The following is a description of a gene set: Genes up-regulated in comparison of control CD4 CD8 thymocytes versus those after stimulation with anti-Valpha2 antibodies. Comparison of gene expression changes in CD4+CD8+ thymocytes following engagement of TCR with anti-Valpha or Vbeta antibodies studied in species Homo sapiens Human Gene Set: GSE1448_CTRL_VS_ANTI_VALPHA2_DP_THYMOCYTE_UP from publication Niederberger N, Buehler LK, Ampudia J, Gascoigne NR (PMID 15661827), and this is the list of marker genes: IFNGR2, ARPC5L, STAG2 (NCBI Gene Id 10735), DPP6, EIF2S3, DNPH1, HPN, ISOC1, ZNF22, TP53BP1, INMT, SMARCA5, TXNRD1, NFYC, CRX, APMAP, MECR, THOP1, LUC7L, RHOG, TAF8, CAD (carbamoyl-phosphate synthetase 2, aspartate transcarbamylase, and dihydroorotase), PNMT, SPAG5, MAP3K4, POLE2, RAB5B, MYH14, ATRX, CCN1, YBX3, HUS1, DPYSL3, UFD1, LRRC57, CHAF1B, NKIRAS2, PRKD3, PROS1, UCHL5, SCMH1, IMP4, FARSB, LSR (NCBI Gene Id 54595), KLRD1, SYT6, ACRBP, WDR75, DDAH2, ALAS2, CNTROB, SH2B3, USP9X, HS3ST3A1, IFT46, MRPL55, PIGU, HNF4G, TSG101, BLCAP, GCSAM, STUB1, TGFBR3, RRP9, BNIP1, AZGP1, UCK1, CENPL, SLC5A1, BCAR1, ANGPT1, PCM1, REPIN1, MAPKBP1, LAMB1, CDC25C, PKD1, HTT, CTSK, SPSB2, PPP5C, RECK, CLIC4, PLPBP, CDC7, PDIA4, NELFA, CEBPB, GFM1, ACP1, SLC25A1, STK25, CDCA3, TFPI2, NAA10, STAU1, NTRK3, C19orf73, TUB (TUB bipartite transcription factor), NRTN, KRTDAP, PMF1 (NCBI Gene Id 94958), CNOT4, FBP2 (fructose-bisphosphatase 2), RPA2, RBM10, USP22, TSC1, MYH8, POU3F3, PPT1, ALAS1, GABRR1, ADCY6, FOXK2, RRBP1, CENPA, TNFRSF1A, DOLPP1, SMOC1, TLR7, BLZF1, HDAC6, UBE2Z, HEMGN, CENPV, DMRTB1, RAD1, SRC, KLC2, KLF1, SHD, AP1S1, FOXM1, PRR15, ZMYM4, CSTF2, TENM2, SLN, SPIB, CEP131, SULT4A1, SPPL2B, HAP1, COPG1, PLOD3, GNAT2, MFAP5, RFC2, NKAIN1, CACNB3, GALNT10, SF3A1, SEMA5A, GCK, TK1, U2SURP, DIPK1B, E2F1, RAD51D, CAPN9, BCL2, PPP2R1B, CYP4A22, CCN5, C1orf174, TULP1, GPR132, RFC3, DDX49, BABAM2, ZNF32, MAPK9, GZMB, SAC3D1, RGR, TUBG2, GTSE1, FLNB, VPS4A, SLC25A6, NEK2, ASPM, SYNE4, RNGTT, PSCA, LMNB2, CDKN1A, PI4KA, GPR27, DHFR, ZFP36, SART1, ZC3HC1, RETREG2, PPIG, FKBP8, HDHD2, CHRNE, DEAF1